The following is a description of a gene set: Mouse Gene Set: TERAMOTO_OPN_TARGETS_CLUSTER_3 Cluster 3: genes whose up-regulation peaked 3 days after knockdown of OPN by RNAi in the NIH3T3 cells (fibroblasts) transformed by activated HRAS. species: Mus musculus Activated forms of Ras family members are prevalent in many cancers where Ras mutants transduce signals essential for transformation, angiogenesis, invasion and metastasis. As a cancer progression model, we used NIH3T3 cells to explore the mechanism of Ras-induced tumorigenesis. Ras family mutants H-RasV12 and Rit79L strongly induced foci formation, while Rho family mutants RhoA-QL, Rac1-QL and Cdc42-QL were less effective. A comparison of downstream transcriptional targets of Ras and Rho family members using a 26 383 element cDNA microarray revealed that the osteopontin (OPN) gene exhibited the best correlation between magnitude of gene expression change and level of foci formation (r=0.96, P<0.001). In association with H-RasV12- and Rit79L-mediated transformation, foci secreted OPN protein and upregulated the OPN receptor CD44, suggesting the novel initiation of an aberrant OPN-CD44-Rac autocrine pathway. In support of this were the following observations. First, RGD-deficient OPN protein-binding activity was present in H-RasV12-transformed cells but not in control cells, and binding activity was inhibited by the CD44 blocking antibody. Second, foci formation, cell invasion and Rac activity were induced by H-RasV12 and inhibited by the CD44 blocking antibody. Third, foci formation by H-RasV12 was substantially reduced by a short interfering RNA (siRNA) specifically targeting OPN expression for knockdown. Fourth, H-RasV12-mediated transformation was not blocked by the GRGDS peptide, suggesting that OPN effects were not mediated by the integrins. Lastly, OPN knockdown affected the downstream expression of 160 '2nd tier' genes, and at least a subset of these genes appears to be involved in transformation. Indeed, four genes were selected for knockdown, each resulting in a disruption of foci formation and/or invasion. These results underscore the role of aberrant autocrine signaling and transcriptional networking during tumorigenesis. from publication Teramoto H, Castellone MD, Malek RL, Letwin N, Frank B, Gutkind JS, Lee NH (PMID 15516973), and this is the list of marker genes: Peg10, Gpr137c, Nip7, Rbm7, Tram2, Sec22c, Pagr1a